The following is a description of a gene set: The process in which a SUMO protein (small ubiquitin-related modifier) is conjugated to a target protein via an isopeptide bond between the carboxy-terminus of SUMO with an epsilon-amino group of a lysine residue of the target protein. Human Gene Set: GOBP_PROTEIN_SUMOYLATION studied in species Homo sapiens, and this is the list of marker genes: SMC6, SAE1, EGR2, ZBED1, SUMO1P1, MDM2, TRPM4, IFIH1, CBX4, SENP5, NSMCE1, TRIM28, EID3, BCL11A, SENP1, SLF2, HMG20B, MAGEA2B, SUMO4, TRIM38, HDAC4, CAPN3, TOPORS, PARK7, EYA1, UBE2I, RNF212, PML, ARNT, RASD2, SENP2, UBA2, KIAA1586, STX1A, CTNNB1, MUL1 (mitochondrial E3 ubiquitin protein ligase 1), HDAC7, RANGAP1, FSCB, PIAS2, HMG20A, SUMO3, MAGEA2, SLF1, TRIM27, PIAS1, NSMCE2, NFATC2IP, RWDD3, SUMO1 (NCBI Gene Id 7341), GNL3, UHRF2, RELA, NSMCE3, ZMIZ2, ZMIZ1, PIAS3, NSMCE4A, TOLLIP, SENP6, GNL3L, ZNF451, EGR1 (NCBI Gene Id 1958), CDKN2A, SMC5, RANBP2, SUMO2, PIAS4